Given this list of marker genes ZCRB1, IRF3, TKFC, RPS16, MOGS, UBA52, ACE2 (angiotensin converting enzyme 2), RPS19, N, 6, RPS27A, ST3GAL2, RPS15A, SFTPD, PARP9, SIKE1, S, TBK1, RPS27, NLRP3, RPS3, VCP, RPS24, CHMP7, RPS15, PIK3R4, VHL, UBB, YWHAB, RPS12, ST3GAL4, RPS28, RPS25, PKLR, BCL2L1, MAVS, PARP4, ST3GAL3, 1a, BST2, 3b, TRAF6, PIK3C3, PCBP2, RPS9, PALS1, CASP1, PYCARD, EP300, NPM1, SUMO1 (NCBI Gene Id 7341), CHMP6, NFKB1, SFN, CTSL, MAP1LC3B, YWHAQ, YWHAE, RCAN3, GSK3A, RB1, RPS4Y1, 18S rRNA, SP1 (NCBI Gene Id 6667), CAV1, RPS27L (NCBI Gene Id 51065), RPS20 (ribosomal protein S20), PARP16, 8b, ST3GAL1 (NCBI Gene Id 6482), NPIPB3, GSK3B, PRKCSH, CHMP4B (NCBI Gene Id 60501, charged multivesicular body protein 4B), ST6GAL1, CHMP4A, KPNA2, BECN1, PARP6, HNRNPA1, SARS coronavirus, complete genome, 9b, NFKBIA, RPS5, SMAD4, RPS21, RPSA, PPIA, CHMP4C, FKBP1A, RPS13 (ribosomal protein S13), STING1, UBE2I, ST6GALNAC4, RIPK3, PPIG, PARP8, DDX5, 3a, rep, PPIB, CHMP2B, RUNX1, RPS18, IFIH1, 7a, ST6GALNAC3, GANAB, RPS10, RPS4X, RPS2, UBC, TLR7, TRAF3, PPIH, RPS4Y2, CHMP2A, YWHAG, RELA, RPS17, RPS7, ST6GALNAC2, RPS8, RIGI, TRIM25, TMPRSS2, RPS29, IRAK2, TOMM70, RPS26, RPS23, M, UVRAG, RPS14, E, CHMP3, GALNT1, KPNB1, CANX, RPS11, PARP14, YWHAH, PARP10, NMI, PSMC6, FAU, RPS3A, RPS6, MGAT1, ITCH, RIPK1, SMAD3, IKBKE, YWHAZ, PDPK1, SERPINE1, EEF1A1, here is a description of the gene set: Reactome Pathway: SARS-CoV-1 Infection species: Homo sapiens The SARS-CoV-1 coronavirus is the causative agent of the outbreak of severe acute respiratory syndrome in 2003 that caused 8,098 known cases of the disease and 774 deaths. The molecular events involved in viral infection and the response of the human host to it have since been studied in detail and are annotated here (de Wit et al. 2016; Marra et al. 2003). Within the endocytic vesicle, host proteases mediate cleavage of S protein into S1 and S2 fragments, leading to S2-mediated fusion of the viral and host endosome membranes and release of the viral capsid into the host cell cytosol. The capsid is uncoated to free the viral genomic RNA, whose cap-dependent translation produces polyprotein pp1a and, by means of a 1-base frameshift, polyprotein pp1ab. Autoproteolytic cleavage of pp1a and pp1ab generates 15 or 16 nonstructural proteins (nsps) with various functions. Importantly, the RNA dependent RNA polymerase (RdRP) activity is encoded in nsp12. Nsp3, 4, and 6 induce rearrangement of the cellular endoplasmic reticulum membrane to form cytosolic double membrane vesicles (DMVs) where the viral replication transcription complex is assembled and anchored. With viral genomic RNA as a template, viral replicase-transcriptase synthesizes a full length negative sense antigenome, which in turn serves as a template for the synthesis of new genomic RNA. The replicase-transcriptase can also switch template during discontinuous transcription of the genome at transcription regulated sequences to produce a nested set of negative-sense subgenomic (sg) RNAs, which are used as templates for the synthesis of positive-sense sgRNAs that are translated to generate viral proteins. Finally, viral particle assembly occurs in the ER Golgi intermediate compartment (ERGIC). Viral M protein provides the scaffold for virion morphogenesis (Fung & Liu 2019; Masters 2006). part of: SARS-CoV Infections